Given this list of marker genes VTA1 (NCBI Gene Id 92752), HOOK3, CLPX, DPYD, ABHD18, RO60, RAB33B, ZNF236, STRN, CCT4, ZSCAN23, NPPC, SCYL2, CNOT2, PLCL1, SLC13A1, TENT5C, DCUN1D5, ERAP1, C1GALT1, SLC24A2, NAA15, NRIP1, RIMKLB, DIAPH3, JADE1 (jade family PHD finger 1), ID2, SOBP, PCDH17, OTUD6A, ELF1, FMR1, ZNF197 (NCBI Gene Id 7719), SOS1, RAP2A, ETV1, UTS2, SH3TC2, PPARGC1A, BPTF, STON1, TCAIM, GLRX3, CTDSPL2, FAT3, TMTC4, RLIM, ZNF704, SENP6, MEX3A, ERCC8, COL8A1, OTUD6B, EIF1AX, S100A14, HYPK, CPXM2, OSBPL8, MAGEA10, PDE12, SLC25A13, YTHDC1, DNAJC3, NEPRO, CDC73, CD109, ADGRL2, SERPINB10, LMO7, PIKFYVE, CFAP91, DSCAML1, NECAP1, SEL1L, CCDC68, PMAIP1 (NCBI Gene Id 9305), CEP170, EYA4, TMED4, PLCXD3, ZNF652, OCIAD1, FAM117B, PRDM4, ZNF682, ELK3, KMT5B (lysine methyltransferase 5B), ITGA6, SESTD1, PRKAR2B, BRSK2, CD47, TM9SF3, ZNF697, PRLR, ATL2, CPEB4, ZNF480, DNAJB14, SEMA5A, HSPA1B, BDH2, PRKG1, EMB, TRAF5, TRUB1, CCDC88A, KLHL24, RCSD1, FEM1C, MXRA5, ITGBL1, NIPA2, FKBP5, SSBP2, ZNF449, STATH, ATRNL1, ADGRF1, MANEA, FAM20B, LRRC31, TAOK1, BORA, PER3, ONECUT2, SIRT7, PNISR, ZBTB20, ZNF506, ANGEL2, PAPPA, EIF4E3, NAPG, VPS13B, EPHA7, GPR180, DDHD1, TMEM97, GNB4, STEAP2, PPP3CA, STXBP5L, CHD9, STIM2, UTY, CD180, RP2, CSNK1G3, MRE11, DLC1, RFESD, TACR1, UGGT1, SATB2, AP4E1, KITLG, PHF14, CCNDBP1, NCOA2, RNF128, ZNF470, TBC1D3D, GNRHR, TBC1D3H, RAD23B, CXCL3, AAK1, ABCB5, PPM1L, KLF12, KAT2B, SLC38A2, DNAAF10, RAD54B, PLCB1, REST, LRRC2, ALDH1L2, C10orf88, SUZ12, ZFAND3, TOX3, ST3GAL6, LIFR, NFIA, PCM1, NRG4 (NCBI Gene Id 145957), ZMYM4, MINDY2, SGIP1, TNIP3, CACNB4, PRRG4, TMX1 (NCBI Gene Id 81542), ZNF845, FNDC3A, DUS4L, EPHA4, RNF138, APOOL, ALG10B, ETS1, PAK2, FGF7, C8orf44-SGK3, GNG2, FMN2, GPR12, ITGA4, RAB1A (RAB1A, member RAS oncogene family), USP10, SLC36A4, TMEM74, TMEM200A, HIPK1, ARRDC3, RAPGEF1, THRB, SMIM10L1, ANOS1, PPP4R2, TBC1D3, MRPL42, PLPPR5, TRIM23, LMBR1, SNX25, ARMC10, PCGF5, EREG, NAPEPLD, ZC3H11A, TSHZ2, SP110, GPRIN3, BAG1, FGA, SFXN1 (sideroflexin 1), GCNT1, DUSP19, WDR7, TEAD1, ELMO1, GABRB3, CASTOR2, TBC1D3C, PABPC4L, RFX3, RND1, ACTR2, CALM1, GOSR1, SLC16A12, FAM98A, RBM11, UBE2G2, SFMBT2, MYRIP, ARID1B, HELQ, SLC30A7, OXTR, ARL6IP5, IPPK, NSFL1C, EIF2A, CRISPLD2, SEMA3A, TRPC3, GPR85, SGK3, KGD4, RYR2, SGCZ (sarcoglycan zeta), RUFY2, ANKRD29, MTO1, IQGAP2, RIC3, MSH4, NRCAM, NAALAD2, ZNF559, TTC33, PALM2AKAP2, LRP2 (NCBI Gene Id 4036), CCDC190, SGTB, ZDHHC21, AMBRA1, PCDHB9, TRPM8, TBCK, CSMD1, ST18, RNF112, FBXO4, MB21D2, RASGEF1A, BICC1, SEMA3C, TMEM41B, ARHGAP42, ZBTB21, MIDN, AKAP8, NAALADL2, NCOA5, MYO6, YTHDF3, TRABD2A, KCNQ5, TLCD4, ZCCHC10, PLOD2, SHOX2, MCUR1, STON2, EDEM3, RNF169, CYP7B1, XPR1, ZCCHC2, LRRC40, CCDC169-SOHLH2, NOM1, SH3D19, PNPT1, MCAM, F2R, GOLGA6L9 (golgin A6 family like 9), PRPF40A, BID, IL1RAP, GRIN3A, TIPARP, COL1A2, NLGN1, CIP2A, C14orf119, SRSF6, ZNF426, CCDC82, MTMR10, RBM46 (RNA binding motif protein 46), ANTXR2, CUL5, ADNP, ZFP36L2, CTBS, MAP7, SH3GLB1, TSHZ1, FAF2, XIRP2, SHC3, NEGR1, BROX, PRKAA2 (protein kinase AMP-activated catalytic subunit alpha 2), RGS7BP, DISC1, HYCC1, ARK2C, YAF2, UBE4A, SAMD5, B3GALNT1, ROCK2, ADAMTS8, EHF, CACNA2D1, SH3KBP1, PIK3CG, NEUROG1, CCT6A, C1orf53, RBMS2 (RNA binding motif single stranded interacting protein 2), ZNF655, CEP68, GABPA, FRS2, STC1, STXBP5, CELF4, HELZ, TMEM260, ARFGEF2, ZNF254, DTL, MARCHF7, SPARC, COBLL1, ZNF23, PREX2, DIP2B, EIF5AL1, CUL3, NOL4, PAX6, SNCA, ITPRID2, LIAS, UBL3, ANK3, KALRN, CDK13, CES2, ACVR2B, HDAC9, SLC17A8, KCNJ5-AS1, CXCL12, MDGA2, TMTC1, PDS5B, NEDD4L, ATP1A2, CRISPLD1, RASSF6, TENT5D, NUDT15, PCSK5, UFL1, BRD1, MRM2, CTNNA2, TBC1D3K, AEBP2, EMC1, TBC1D3F, HERC3, SWAP70, LMO4, XYLB, RBM7, WASHC3, CDKN1B, NCOA7, ARFGEF3, ELAVL2, PCBP1, FOS, SLC49A4, CENPJ, RPS6KB1, C2CD6, EIF4B, ZFP1, APLP2, ZNF786 (NCBI Gene Id 136051), ZBTB10 (NCBI Gene Id 65986), GXYLT1, ZFX, STK38L, PHF24, MUCL3, ZNF681, YIPF6, SLC9A2, ZNF208, HERC2, SLCO1A2 (solute carrier organic anion transporter family member 1A2), SEMA3D, PRR14L, SLC9A7, MBTD1, ZFHX3, TMPRSS11D, ASB8, P2RY1, TMEM131L, NTRK2 (NCBI Gene Id 4915), TMEM106B, CDKL2, SYT4, PPM1E, TMEM33, CACNG2, GLYATL3, GPR171, GTF2H5, TBL1XR1, TMEM237, CFL2, SUCLG2, CYRIA, UBE2D1, SMAD5, ERICH2, ATP1B4, PGM2L1, PA2G4, GOLGA6L4, FUT9, WNT3, CSRNP3, CCDC186, DCUN1D1, ACADSB, ANKRD13C, MYCN, PIGV, KDM7A, MAGEE1, PARVA, SLC26A7, USP29, SHROOM3, BCAR3, CEP135, PLCB4, PRMT2, PARP11, ADAMTS6, FEZF1, FPGT, TNFSF13B, PDGFD, NUP98, GRIN2A, MOSPD2, HTR2A, CNTN5 (contactin 5), LTN1, HDGFL2, SEPTIN14, CCDC85A, TTC21B, AKAIN1, SMARCA5, KCND2, OPRM1, DENND4C, SIX4, THSD7A (thrombospondin type 1 domain containing 7A), SMARCE1, STRBP, TAOK3, KCTD9, GSKIP, THAP2, PIK3CA, BEND6, KLHL28, MXI1, GASK1B, FER, NUFIP2, LMOD2 (NCBI Gene Id 442721), RC3H1, UBE2W, KCNH7, RBM12, MAPK9 (NCBI Gene Id 5601), ZFP69, MAP2K1, VAPB, NAV1 (NCBI Gene Id 89796), FGF12, FZD3, GPM6B, LRATD2, CLVS2, MEI4, CDH15, ROBO1, MAGI3, VAPA, ISCA1, SMIM14, PXDN, NCKAP1, VPS29, PALLD, OTUD4, PRTG, GNPNAT1, CHPF2, ALKAL1, SBNO1, RPGRIP1L, WWTR1, ADRA1A, DHX58, SOWAHC, CCSER1, TCF4, LRRN1, FEM1B, CORO2A, PTEN, MMRN1, ENPP4, OPN3, NEK1, SLC25A17, AFF4, G6PC2, CNTN1, ADAM12, ZNF99, ADO, GOLGA2, FLRT3, RORA, HAPLN1, KCTD4, HSD17B12, NPAS3, CYP7A1, STARD3NL, ANXA7, PROSER2, ARL15, ODF2L, CHD2, GUCY1A2, RAB30, ANK1, PTAR1, NAP1L1, ZEB2 (zinc finger E-box binding homeobox 2), HTR2C, TXNRD1, CCDC170, KRAS, PDE1A, ZHX1, HBS1L, ARL5A, MTRF1L, CREBRF, ZBTB18, HOXA13, ECT2L, PLEKHM3, PPAT, TBX15, CD200, TLL2, MACC1, PHIP, LMAN1, SST, OTOA, ITGA8, KLHL9, KAZN, MAGT1, SLC5A3, C6orf58, ASXL3, EIF3E, TRNP1, NDST3, STARD13, PARPBP, LPGAT1 (lysophosphatidylglycerol acyltransferase 1), HLCS, LARP4B, EZR, HOMER1, TRIM9, DEFB132, RUNX1T1, IL16 (interleukin 16), BCL11A, RAB8B, FH, CACUL1, JCAD, EFNA5, TMEM167B, POGLUT1, MEGF10, ZBTB33, SERPINE2, SPTSSA, ADI1, GABRB2, LSAMP, UBE2D4, MPC1, NHSL1, KPNA4, LHFPL3, TANC2, THAP9, ZFP36L1, DENND1B, LRRTM2, SLC30A5, PCLO, SCN3B, GPAM, AHDC1, WDR17, ELN, ELAVL3, SAR1B, ZNF345, AFF2, ARMC1 (NCBI Gene Id 55156), AK7, NIPA1, TRA2B, FGF18, ITGB6, CNPY2, SEPSECS, GIGYF1, GRM5 (NCBI Gene Id 2915), ZNF793, CCDC50, ELOVL7, EGR3, MCTP2, CREBZF, TMEM178B, GPN3, USP15, NAA30, LCORL, PHACTR2, LINC02801 (long intergenic non-protein coding RNA 2801), TPH2, GRID2 (glutamate ionotropic receptor delta type subunit 2), ZNF32, ZNHIT6, SOHLH2, DERA, PTCHD4, CERS6, PDIK1L, TBC1D3B, TTBK2, TBC1D4, TMED5, ABCD2, SLC4A4, EDNRA, TBC1D3L, PSMD14, VCAN, PCDH7, RPRD1B, TCAF2, PUM2, DMRT2, VSIG10, CHRNA5, NKAIN3, OGN, GGA1, HOXD13, IGSF3, LYPLAL1, KCNT2, ZNF92, ADAMTS1, STRIP2, SERPINB13, FUT8, CD200R1, CPNE3, LRRTM3, PAX8, ARID4B, TOE1, CNTRL, ERBB4, CNTNAP5, MRTFB, NR3C1, ABHD5, PRKCI, KIN, SLC19A2, CYBRD1, ZNF322, ANKRD50, SBSPON, GPATCH2L (NCBI Gene Id 82392), LHX9, SLC7A11, ZFP42, CASR, CLIC2, SPN, SLC9C1, IFT70B, JMY, DIAPH1, ERC2, TLCD5, CEP350, BBS7 (NCBI Gene Id 55212), RIC1, ULBP1, NR2E3, NCEH1, MSI2, PRRG3, RTL9, APPL1 (NCBI Gene Id 26060), B3GNT5, KLHL13, SYT14, RBMS3, PCMTD1, SLC17A6, PTGDR, ZNF718, ADAM32, RNF217, TCEAL1, PGAP1, IFT81, DYRK1A, CYB5B, DGLUCY, CRIPT, INSIG1, NECAB1, DST, FRMD4B, ZNF430, BRCC3 (BRCA1/BRCA2-containing complex subunit 3), POU2F1, ATAD1, GHR, CLDND1, MED14OS, KIAA0408, ATG4C, GBP5, SEPHS2, FGF9, ERP44, ACSL6, BLOC1S5, XRCC4, ITGB8, INTS14, MINAR1, LRP1B, HSCB, AGFG1, ACVR1C, ETF1, IRX2-DT, PIN4, PARN, TBC1D3I (TBC1 domain family member 3I), ATP6V1G1, SAMD8, PBRM1, ZBTB7A (zinc finger and BTB domain containing 7A), NT5C3B, RTN3, RPS6KA3, USP34, ACSM5, ATAT1, NDUFA1, ZIC3, RMND5A, RPS6KA1, SSB, PPIL1, ZC3H6, PDE1C (phosphodiesterase 1C), SPOP, MSRB3, NETO1 (NCBI Gene Id 81832), PHLPP2, CPT1A, COL4A1, NAA35, BCOR, HYCC2, SRPK2, here is a description of the gene set: Genes predicted to be targets of miRBase v22 microRNA hsa-miR-335-3p in miRDB v6.0 with MirTarget v4 prediction scores > 80 (high confidence targets). from publication Chen Y, Wang X (PMID 31504780) Human Gene Set: MIR335_3P species: Homo sapiens